Given this list of marker genes Gak, Lats1 (NCBI Gene Id 16798), Hnf4a, St3gal2, Ankrd50, Themis, Mecp2, Rad9a, Rbm28, Osbp (oxysterol binding protein), Slc13a1, Ifit1bl1, Vezf1, Usp27x, Matn3, Slc30a7, Usp42, Eif4e (eukaryotic translation initiation factor 4E), Nwd2, Amacr, Gtf3c2, Sytl5, Lrrc10 (NCBI Gene Id 237560), here is a description of the gene set: Mouse Gene Set: MIR_695 Genes predicted to be targets of miRBase v22 microRNA mmu_miR_695 in miRDB v6.0 with MirTarget v4 prediction scores > 80 (high confidence targets). studied in species Mus musculus from publication Chen Y, Wang X (PMID 31504780)